Given this list of marker genes ARHGEF16, ARHGEF6, FGD3, ARHGAP22, CDC42EP5, ARAP1, GOLGA8R, PIK3R2, FGD2, ARHGEF9, ARHGAP32, ARHGAP9, DOCK10, KTN1, TAGAP, PLEKHG2, PLEKHG3, CDC42EP1, PAK5, LAMTOR1, ARAP3, BAIAP2, MYO9B, DOCK9, ARHGAP39, GIT1, ARHGAP24, CDC42SE2, ARHGAP17, GMIP, FMNL2, ARHGAP40, GNA13, DOCK6, OPHN1, TMPO (NCBI Gene Id 7112), ARHGEF15, DOCK8, ARAP2, CDC42BPB, CDC42, SRGAP2, SYDE1, VAMP3, ARHGAP21, STOM (NCBI Gene Id 2040), PREX1 (NCBI Gene Id 57580), KCTD3, SNAP23, WAS, LBR, DEPDC1B, PAK6, GIT2, CAV1, CHN1, SRGAP3, RASGRF2, ARHGEF7, STARD13, ARHGAP26, ECT2, ARHGAP31, ARHGEF5, JUP, WIPF1, RALBP1, ARHGEF10, FAM13B, ARHGAP5, ABR, RACGAP1, CDC42EP3, DLC1, ARHGAP20 (Rho GTPase activating protein 20), CDC42EP4, ARHGAP27, ARHGAP1 (NCBI Gene Id 392), PLEKHG1, MCF2, MCF2L, ARHGAP10, PAK3, FARP1, ARHGDIA, WDR81, SPATA13, PAK1, ARHGEF25, VAV3, ARHGAP44, MAP3K11, ARHGAP33, FMNL3, TFRC, YKT6, PAK2, ARHGDIB, ARHGEF4, WIPF2, VANGL1, STEAP3, WASL, ARHGEF26, PLEKHG4B, CDC42BPA, NGEF, ARHGEF12, DOCK11, VAV2, DAAM1, SRGAP1, TIAM1, RAB7A, WDR91, ARFGAP3, IQGAP1, PREX2, ARHGAP11B, ARHGDIG, FNBP1L, SH3PXD2A, DNMBP, DEF6, CDC42EP2, PLD1, FGD1, PAK4, DOCK7, SCRIB, PIK3R1, CPNE8, ARHGAP30, STARD8, WIPF3, ARHGAP45, ARHGAP29, DIAPH3, FNBP1, ITSN1, ARHGEF19, FMNL1, FGD4, BCR, ARFGAP2, PLEKHG4, ARHGAP42, TRIO, ARHGEF11, SHKBP1, PARD6A, ARHGAP4, ARHGAP35, IQGAP2, IQGAP3, here is a description of the gene set: part of: RHO GTPase cycle This pathway catalogues CDC42 guanine nucleotide exchange factors (GEFs), GTPase activator proteins (GAPs), GDP dissociation inhibitors (GDIs) and CDC42 effectors. CDC42 is one of the three best characterized RHO GTPases, the other two being RHOA and RAC1. By regulating the cytoskeleton, CDC42 regulates cell polarity across different species, from yeast to humans. CDC42 is an essential regulator of polarized morphogenesis in epithelial cells, where it coordinates formation of the apical membrane and lumen formation, as well as junction maturation. CDC42 plays a role in cell-to-cell adhesion and cell cycle regulation. CDC42 takes part in the regulation of membrane trafficking. Dysfunction of several CDC42-specific GEFs has been shown to impair intracellular trafficking. CDC42 participates in insulin synthesis and secretion and contributes to the pathogenesis of insulin resistance and diabetic nephropathy. CDC42 is often dysregulated in cancer because a number of GEFs and GEF activators that act upstream of RAC1 and CDC42 are known oncogenes. CDC4 promotes cancer cell proliferation, survival, invasion, migration and metastasis, especially under hyperglycemia. Reactome Pathway: CDC42 GTPase cycle studied in species Homo sapiens